The following is a description of a gene set: Human Gene Set: REACTOME_TNFS_BIND_THEIR_PHYSIOLOGICAL_RECEPTORS species: Homo sapiens TNFs bind their physiological receptors, and this is the list of marker genes: TNFSF11, TNFRSF14, TNFRSF17, TNFSF13B, TNFSF8, FASLG, TNFSF4 (NCBI Gene Id 7292), TNFRSF13B, CD70, TNFRSF8, TNFSF13 (NCBI Gene Id 8741), EDARADD, TNFSF18, TNFSF9, TNFRSF25, EDAR, TNFRSF1A, TNFSF14, TNFRSF11B, EDA2R, TNFRSF9, CD27, TNFRSF18, TNFRSF1B, LTA, TNFRSF6B, TNFSF15, EDA, TNFRSF4